Given this list of marker genes CAMKK2, HTT, KCNJ11, IRGM, MYH7B, TREM2, ZMPSTE24, KCNJ8, LRRK2, PCP4, PRKAA1, here is a description of the gene set: The series of molecular signals in which calmodulin-dependent protein kinase activity enabled by a CAMKK directly activates an AMPK. The cascade begins with calmodulin binding calcium which in turn binds CAMKK enabling its calmodulin-dependent protein kinase activity. The cascade ends with AMP-activated protein kinase activity. Human Gene Set: GOBP_CAMKK_AMPK_SIGNALING_CASCADE species: Homo sapiens